Given this list of marker genes HOXD10, CLASP2, PSMD11, TMED7, KBTBD2, CDK6, CUX1, SPC24, JADE1, NCAPG2, RBM41, MAPK9, DCLK1, DPP10, SBNO1, SAMD12, PAFAH1B1 (NCBI Gene Id 5048), ZBTB43, CLDN11, SEMA3C, SEPSECS, DCC, MYNN, NAP1L5, EML6, ADAMTS3, RORA, KLHL2, HERC1, SNX13, TMEM135, CWC27, XPO1, CBLL1, TET3, SMIM13, KCTD9 (potassium channel tetramerization domain containing 9), KPNA4, ZFX, ATXN1, KDM7A, MYCN, NONO, ADGRA1, ZNF737, TSHZ3 (teashirt zinc finger homeobox 3), DGKK, B4GALT5, CCDC50, TMSB15A, PPP2R2C, BCL7A, TIPRL, UBE2H, BCOR, SUMO1, ARPP21, FBN2, GAN, ZC3H12C, KCNB2, RBMS1, CCN3, HYCC2, ZFHX4, HEY1, TMEM170B, HMGCS1, CSDE1, ADCY2, DAPK1, RAI14, SEC63, here is a description of the gene set: Human Gene Set: MIR501_3P_MIR502_3P studied in species Homo sapiens Genes predicted to be targets of miRBase v22 microRNA hsa-miR-501-3p, hsa-miR-502-3p in miRDB v6.0 with MirTarget v4 prediction scores > 80 (high confidence targets). from publication Chen Y, Wang X (PMID 31504780)